Given this list of marker genes FBXL2, DYNC2LI1, DIAPH2, SENP6, CYRIA, FAM83C, CFAP47, MTCL2, BCAS2, PROSER2, IGSF6, SLITRK3, APCDD1L, PTCHD4, DNAJC24, SULT1C4, BTN3A3 (butyrophilin subfamily 3 member A3), EPC1, C6, OPTN, YLPM1, MEGF9, CCNT1, ITGB8, EFL1, PPT1, PRKAA1, PROS1, PTPN23 (NCBI Gene Id 96248), ENTPD1, RUBCN, KIF16B, PHF6, BTN3A1, FLT1, TTC9, PHF14, NAP1L1, EPC2, KPNA4, RPA1, MASP1, JAZF1, USP37, TTC39A, ARMCX3, ACAT2, WARS2, PGR, FXR1, TRDMT1, FGF12, BTN3A2, STMN4, ARHGEF38, SLC35D1, ZNF286A, JHY, F13A1, GLIPR1L1, SHISA7, DLG1, ZNF853, MARK4, CRACDL, AMMECR1, FAM135A, PDS5B, LRAT, ZNF638, TWSG1, MRTFB, FUT9, GPR65, DDX46, NKAIN2, GRIA4, FRMPD4, WFDC8, SLC24A2, EDAR, SRP14, ZNF540, DIAPH3, ZNF286B (NCBI Gene Id 791117), here is a description of the gene set: Human Gene Set: MIR3682_3P from publication Chen Y, Wang X (PMID 31504780) studied in species Homo sapiens Genes predicted to be targets of miRBase v22 microRNA hsa-miR-3682-3p in miRDB v6.0 with MirTarget v4 prediction scores > 80 (high confidence targets).